Given this list of marker genes MRPS7, TIMM23 (NCBI Gene Id 100287932, translocase of inner mitochondrial membrane 23), RARS2, NEFH, SLC31A1, NUP188, FRMD4B, NSFL1C, RARS1, DNAJC27, RBM28, CCR7, PPM1G, CRLS1, AKAP1, PRDX3, PYCR3, CDC20, GCNT1, H4C14, XRCC5, GRSF1, SMYD2, G3BP1, SND1, HSP90AA1, H2BC1, TMEM209, PPIE, FASTKD3, AARSD1, SPATA24, HNRNPDL, NIP7, MTSS1, TADA2A, NARS1, CEP83, HUS1, PSMC4, POLR2C, CCT8, MRPS31, CD81, GRWD1, MFSD2A, GFPT1, DDX39A, VARS1, TMEM11, MARCKS, WIPI2, GCSH, WARS1, DYNLT3, PSMD3, MRPL38, HAT1, GCN1, NAF1, CENPS, BBS7, PNO1, AMD1, RBM34, MRPL17, UTP15, TXN2, THAP7, CHST2, MRM3, S100A5, MAGOHB, EIF1AX, ALKBH5, MRPS25, BAG2, LIF, RBM26, NETO2, MRPL23, POLR2D (NCBI Gene Id 9393), NOC4L, TYW3, PDHX, CTNNAL1, TMEM184B, TPST1, NDUFA12, GUF1, NIFK, PREP (prolyl endopeptidase), RPL28, NUDT1, TYSND1, NT5DC3, EIF3G, POLR3E, WDR36, THOC3, YBX1, EIF4G1, SYPL1, ERLIN1, HPDL (4-hydroxyphenylpyruvate dioxygenase like), DYNLL2, ALDOA, PCDHB6, QTRT1, DHX38, KLHDC4, BCAT1, EIF2B3, SHMT2, MORN4, ELAC2, NAT10, BARHL1, UTP3, NAA20, TRMT1, IARS1, ST7, METAP2, ERH, FUBP1, VDAC1, TRMT6, PES1, PPP1R7, NOMO1, OXSR1, NEK6, PFKP, TNPO1, INTS3, GDPD1, DNAJA3, MTREX, MDC1, PSMB6, RFC2, SREK1IP1, HSD17B12, WDR75 (WD repeat domain 75), AHSA1, CCNH, SLC3A2, TMEM97, MRPL49, NAA38, EMC4, SLC12A2, UBAP2L, RRP8, CLASP1 (cytoplasmic linker associated protein 1), NUP43, CIMAP1C, MRPL46, MCPH1, RPL10, SNRPA1, PHF5A, SHMT1, TACC2, RWDD4, EFTUD2, PPWD1, PSMD7, SNRPD1, DCTD, ZC3H8, here is a description of the gene set: Genes up-regulated in macrophages: 5 days with IL4 and dexamethasone followed by TGFB1 for 24h versus 5 days with IL4 followed by TGFB1 for 24h. The goal of the study was to identify the effects of TGF-beta on primary human macrophages maturated under different conditions. species: Homo sapiens Human Gene Set: GSE7568_IL4_TGFB_DEXAMETHASONE_VS_IL4_TGFB_TREATED_MACROPHAGE_UP from publication Gratchev A, Kzhyshkowska J, Kannookadan S, Ochsenreiter M, Popova A, Yu X, Mamidi S, Stonehouse-Usselmann E, Muller-Molinet I, Gooi L, Goerdt S (PMID 18453574)